Given this list of marker genes RRM2B, FN1, TRAPPC2, MT-TL1, CHST3, COL2A1, COL9A1, LTBP3, BPNT2, MT-ATP8, here is a description of the gene set: studied in species Homo sapiens Human Gene Set: HP_INTERVERTEBRAL_SPACE_NARROWING Decreased height of the intervertebral disk. Intervertebral space narrowing